Given this list of marker genes Ppp3ca, Gorasp1, Cit, Gsk3b, Rapgef2 (NCBI Gene Id 76089), Trpc6, Id1, Trpc5, Nfatc4, Ywhah, Dpysl5, Tlx2, here is a description of the gene set: Mouse Gene Set: GOBP_NEGATIVE_REGULATION_OF_DENDRITE_MORPHOGENESIS Any process that stops, prevents, or reduces the frequency, rate or extent of dendrite morphogenesis. species: Mus musculus